The following is a description of a gene set: Urea cycle and associated pathways species: Homo sapiens Human Gene Set: WP_UREA_CYCLE_AND_ASSOCIATED_PATHWAYS, and this is the list of marker genes: OTC, ASS1, NOS1, LDHB, GOT2, ARG1 (arginase 1), MDH1, GOT1 (glutamic-oxaloacetic transaminase 1), NOS3, ASL, OAT, SLC25A15, NOS2, SLC25A13, GLS2, CPS1, PYCR1, FH, GLUD1, ALDH4A1, SLC25A12, NAGS, MDH2, GPT